The following is a description of a gene set: Mouse Gene Set: GOBP_RESPONSE_TO_PEPTIDE_HORMONE studied in species Mus musculus Any process that results in a change in state or activity of a cell or an organism (in terms of movement, secretion, enzyme production, gene expression, etc.) as a result of a peptide hormone stimulus. A peptide hormone is any of a class of peptides that are secreted into the blood stream and have endocrine functions in living animals., and this is the list of marker genes: Smarcc1, Pcsk9, Cyp11a1, Alpl, Mas1, Serpina3m, Stat2, Npr2, Ereg, Inhba, Mapk1, Zfp36l1, Agrp, Serpina1c, Mapk3, Kdm6a, Ahcyl1, Gcnt1, Pomc, Epha7, Cyp11b1, Serpina1e, Ggh, Mstn, Oxt, Tgfbr3, Eef2k, Igf2, Srd5a2, Akr1c18, Bcar3, Erbb2, Epm2aip1, Ncoa1, Sos2, Tshr, Slc24a4 (solute carrier family 24 (sodium/potassium/calcium exchanger), member 4), Csk, Ptpn11, Tcf12, Enpp1 (ectonucleotide pyrophosphatase/phosphodiesterase 1), Adrm1, Th (NCBI Gene Id 21823), Fbp1, Phip, Zfp592, Mst1r, Serpina3k, Bglap, Nfkb1, Erbb4, Adipoq, Socs1, Prkcz, Akt3, Stxbp3, Blvrb, Adm, Stat4, Serpina3f, Pxn, Ptprj, Inhbb, Otop1, Cdkn1b, Dennd4c, Ins1, Fos, Ppp3ca, Rap1gds1, Slc2a8, Cfl1, Rhoq, Raf1, Fgfr1, Agtrap, Rbp4, Vps13c, Stk11, Tbc1d4, Opa1, Plcb1, Vgf, Flt4, Mapk14, Sirt6, Nr4a3, Irs4, Ahsg, Fgfr2, Map3k7, Prkaa1, Serpina3i, Agtr1b, Epha2, Capn10, Eif4ebp1, Bglap3, Rb1, Hnrnpk, Prkar1a, Rac1, Srsf3, Epha10, Crhr2, Hras, Crhbp, Agt, Socs2, Flt3, Mapkap1, Sik2, Col3a1, Usf1, Rbx1, Hsd11b2, Socs3, Scly, Ptprf, Sesn2, Epha5, Map2k1, Gsk3b, Scnn1a, Gpr173, Musk, Serpina1d, Sco1, Il1b, Cited1, Prkcq, Ltk, C2cd5, Gcgr, Ogt, Fgfr4 (NCBI Gene Id 212063), Insig2, Pnpt1, Cpeb1, Gjb2, Cry2 (cryptochrome circadian regulator 2), Wnt1, Dag1, Rock1, Pik3r2, Ceacam1, Ctnnb1, Mtor (NCBI Gene Id 80612), Rangap1, Ephb4, Map1b, F7, Irf1, Gcg, Rps6kb2, Ntrk3, Pax6, Gpt, Flt1, Eif2b4, Kl, Max, Tgfb1, Zbtb7b, Inpp5k, Foxo1, Cat, Pip4k2a, Eif2b3, Wdtc1, Cybb, Bsg, Kat2b, Prkaca, Ache, Tnfsf10, Umodl1, Hadh, Ghr, Stat5a, Pou4f2, Sesn3, Glp2r, Xbp1, Ceacam2, Esrra, Ptk2, Zbed3, Pip4k2c, Ins2, Insrr, Ephb2, Agtr1a, Mup5 (NCBI Gene Id 17844), Areg, Ass1, Appl2, Sort1, Ncl, Epha1, Btg2, Fer, Acvr1c, Mir143, Slc25a33, Eif2b2, Trim72, Srebf1, Leprot, Igf1, Brip1, Tsc1, Mdm2, Igf1r, Serpina1a, Rps6kb1, Cav2, Epha6, Pparg, Inppl1, Reg3g, Cyfip1, Egfr, Abcc2, Gpr21, Ret, Cdo1, Scap, Srsf5 (NCBI Gene Id 20384), Srsf6, Grb10, Akt1, Phb1, Crhr1 (NCBI Gene Id 12921), Camk2a, Gnas, Trim24, Hadha, Slc2a4, Shoc2, Ang2, Kit (KIT proto-oncogene receptor tyrosine kinase), Itgb3, Socs7, Lpin1, Aanat (NCBI Gene Id 11298), Col6a1, Agtr2, Pik3ca, Foxc2, Csf1r, Braf, A1bg, Bglap2, Pdgfra, Star, Gpam, Ndel1, Ros1, Dnai1, Atp2a1, Ccna2, Ntrk2, Aldob (NCBI Gene Id 230163), Gstp1, Got1, Ffar3, Nr4a1, Uprt, Slco1b2, Nfe2l2, Serpina1b, Irs3, Stat1, Khk, Mc4r, Rps6-ps4, Osbpl8, C1qtnf12, Vwa2, Cyp11b2 (NCBI Gene Id 13072), Ace, Leprotl1, Nudc, Ptprv, Sp7, Lonp1, Lhcgr, Grk2, Rab8a, Hhex, Phex, Abcb1a, Fgfr3, Src, Lpin3, Gck, Apc, Sgcb, Gnai2, Tyro3, Tns2, Stc2, Rbm4, Gper1, Myo5a, Meak7, Snx5, Myo1c, Pdgfrb, Ccnd3, Sirt1, Pfkfb1, Klf15 (Kruppel-like transcription factor 15), Grb2, Slc26a6, Prkca, Ccl2, Eif4ebp2, Pklr, Pdk4, Hmga1, Mup3, Kcnq1, Serpina3n, Trpv1, Pkm, Rab10, Ywhag, Actn2, Ghsr, Lrrc25, Ankrd26, Nono, Gatm, Pten, Prkcb, Hmgcs2, Grb7, Foxo4, Gpr82, Lep, Ncoa5, Tnf (NCBI Gene Id 21926), Ikbkb, Gnrhr, Ntrk1, Ephb3, Kank1, Cdk2, Obp2a, Pak1, Cacybp, Timp1, Ppara, mt-Cytb, Slc2a1, Ptpra, Retn, Axl, Reg1, Bcar1, Insig1, Kdr, Eprs1, Comt, Cyp27b1, Adcy6 (NCBI Gene Id 11512), Cela2a, Fut7 (fucosyltransferase 7), C1qtnf9, Prkcd, Irs1, Stxbp4, Eif2b1, Nr5a1, Serpina3c, Gsk3a, Echdc3, Sts, Tie1, Rab13 (RAB13, member RAS oncogene family), Mir423, Jak3, Prlh, Serpina3h, Il18, Pik3r1, Ide, Il10, Adipor1, Nr3c2, Zfp106, Ucp2, Prkd1, Vamp2, Glp1r, Bmp7, Gpld1, Eif2b5, Cps1, Cp, Oprk1, Slc27a1, Cd2ap, Igfbp5, Tnfrsf11a, Lrp5, Syap1, Gria1, Reg2, Ghrhr, Ddr1, Jak2, H2az1, Rps6, Tsc2, Cul7 (NCBI Gene Id 66515), Gja1, Pdpk1, Atp2a2, Ucp3, Rarres2, Mir494, Ephb1, Epha3, Lpl, Rab31 (RAB31, member RAS oncogene family), Rock2, Fam114a1, Rela, Sp1, Creb1, Pld2, Grb14, Apoc3, Scnn1b, Galp, Ror2, Errfi1, Mzb1, Adcy8, Scnn1g, Nucb2, Crk, Sos1, Gh, Cul3, Cad, Gip, Cav1, Col1a1, Irs2, Mup11, Prkcg, Lyn, Sh2b2, Mgarp (mitochondria localized glutamic acid rich protein), Nefl, Sgk1, Slc27a4 (solute carrier family 27 (fatty acid transporter), member 4), Ptpn1, Trpv4, Plcd1 (NCBI Gene Id 97538), Stat5b, Igfbp1, Zdhhc7, Hsf1, Prkci, Shc1, Capn1, Ggcx, Pik3r3, Gdf15, Mfn2, Ctsd, Serpina3g, Oxtr, Slc39a14, Trib3 (tribbles pseudokinase 3), Gclc, Lpin2, Sorl1, Mup4, Fbxw8, Mertk, Nkx6-1, Anxa5, Mup2, Iqgap1, Egr2, Stat6, Prkdc, Nucks1, Ncoa2, Ptgs2, Uchl3, Otc, Eif6, Pcsk1, Egr1, Pip4k2b, Pck2, Tyk2, Epha8, Adora2b, Uso1, Slc30a10, Appl1, Ptpn2, Cyc1, Kcnj8, Atp2b1, Epha4, Edn1, Nck1, Smad3, Pdk2, Alk, Stat3, Gkap1, Nr4a2, Nr1h4, Mup1, Reg3a, Cry1, Cpeb2, Hdac9, Tek, Ddr2, Ctsk, Insr, Mbd5, Akt2, Csrp3, Btg1, Pck1, Trarg1, Mtcl2, Nos1, Erfe, Lta4h, Parp1, Serpina12, Pde3b, Pid1 (NCBI Gene Id 98496), Met, Cyp1b1, Kbtbd2, Slc9a1, Reg3d, Ednrb, Fbn1, Car2, Jak1, Reg3b, Ptpre, Ednra, Chuk (NCBI Gene Id 12675), Marcks, Blvra, Sorbs1 (sorbin and SH3 domain containing 1), Pld1